The following is a description of a gene set: The APC gene encodes the adenomatous polyposis coli tumour suppressor protein, germline mutation of which characterizes familial adenomatous polyposis (FAP), an autosomal intestinal cancer syndrome. Inactivation of APC is also recognized as the key early event in the development of sporadic colorectal cancers, and its loss results in constitutive activity of the beta-catenin-Tcf4 transcription complex. The proto-oncogene c-MYC has been identified as a target of the Wnt pathway in colorectal cancer cells in vitro, in normal crypts in vivo and in intestinal epithelial cells acutely transformed on in vivo deletion of the APC gene; however, the significance of this is unclear. Therefore, to elucidate the role Myc has in the intestine after Apc loss, we have simultaneously deleted both Apc and Myc in the adult murine small intestine. Here we show that loss of Myc rescued the phenotypes of perturbed differentiation, migration, proliferation and apoptosis, which occur on deletion of Apc. Remarkably, this rescue occurred in the presence of high levels of nuclear beta-catenin. Array analysis revealed that Myc is required for the majority of Wnt target gene activation following Apc loss. These data establish Myc as the critical mediator of the early stages of neoplasia following Apc loss. from publication Sansom OJ, Meniel VS, Muncan V, Phesse TJ, Wilkins JA, Reed KR, Vass JK, Athineos D, Clevers H, Clarke AR (PMID 17377531) Mouse Gene Set: SANSOM_WNT_PATHWAY_REQUIRE_MYC studied in species Mus musculus Wnt target genes up-regulated after Cre-lox knockout of APC in the small intestine that require functional MYC., and this is the list of marker genes: Actl6a, Ascl2, Slc1a3, Skp1, Parp1, Gemin2, Mtap, Fzd6, Bmp7, Sox17, Sox4, E2f1, Fzd7, Rock1, Cul1, Sox9, Ptgs2, Slc1a5, Nkd1, Dvl3, Sema3c, Cited1, Myc, Ror2, Tnfrsf19, Dvl2, Nlk, Tcf7, Apod, Ruvbl1, Ldb1, Id2, Igfbp2, Lef1, Smc4, Rabep2, Ccn4, Fxn, Pcbd1, Trp53, Ephb2, Edn1 (NCBI Gene Id 13614), Wif1, Frzb, Ptch1, Foxa1, Ccne2, Plat, Id3, Msx1, Csnk2a1, Bax, Arx, Ephb3, Sp5, Lgr5, Tiam1, Lect2, Mmp14, Sim2, Tnfrsf12a (NCBI Gene Id 98086), Axin2, Cd44